The following is a description of a gene set: species: Homo sapiens part of: Homology Directed Repair Reactome Pathway: HDR through Homologous Recombination (HRR) or Single Strand Annealing (SSA) Homology directed repair (HDR) of replication-independent DNA double-strand breaks (DSBs) via homologous recombination repair (HRR) or single strand annealing (SSA) requires the activation of ATM followed by ATM-mediated phosphorylation of DNA repair proteins. ATM coordinates the recruitment of DNA repair and signaling proteins to DSBs and formation of the so-called ionizing radiation induced foci (IRIF). In a process involving RAD52, the direct repeats in each 3'-ssDNA overhang become annealed, the unannealed 3'-flaps excised, and structures then processed by DNA repair synthesis. SSA results in the loss of one of the annealed repeats and the DNA sequence between the two repeats. Therefore, SSA is error-prone and is probably used as a backup for HRR, with RAD52 loss-of-function mutations being synthetically lethal with mutations in HRR genes, such as BRCA2., and this is the list of marker genes: CCNA1, RTEL1, FIGNL1, POLE, NSD2, SUMO2, MUS81, CLSPN, TIMELESS, TOPBP1, ATM, SPIDR, LIG1, UBC, H2BC4, RAD51C, BRIP1, H2BC21, FIRRM, H2BC9, NBN, RMI1, RFC5, RAD51B, RAD52, H4C1, POLD4, H2BC15, H2BC1, CCNA2, ABL1, H2BC3, HUS1, RFC2, RFC3, RPS27A, PALB2, RAD51AP1, RHNO1, H2BC26, RAD51, RMI2, RNF8, SEM1, DNA2, POLK, ATR, H2BC12L, TP53BP1, H2BC13, RFC4, HERC2, UBB, RFC1, PIAS4, GEN1, TIPIN, EME2, PPP4R2, SLX1A, RNF168, EXO1, RPA2, EME1, XRCC2, POLE4, PCNA, H2BC14, RAD9B, RAD50, TOP3A (NCBI Gene Id 7156), UBA52, H2BC11, POLE3, UIMC1, PPP4C, WRN, ERCC4, BLM, POLD1, CDK2, BRCA2, BRCA1, H2AX, BRCC3, POLD3, H2BC17, RAD9A, POLD2, RAD17, SIRT6, MRE11, RPA1, ABRAXAS1, BABAM2, CHEK1, MDC1, H2BC12 (NCBI Gene Id 85236), RAD1, POLH, BARD1, SLX4, ERCC1, H2BC5, RPA3, ATRIP, RAD51D, XRCC3, BABAM1, RNF4, KAT5, RBBP8, UBE2N, UBE2I, POLE2, H3-4, UBE2V2